The following is a description of a gene set: from publication Kauffmann A, Rosselli F, Lazar V, Winnepenninckx V, Mansuet-Lupo A, Dessen P, van den Oord JJ, Spatz A, Sarasin A (PMID 17891185) We have identified a gene-profile signature for human primary malignant melanoma associated with metastasis to distant sites and poor prognosis. We analyse the differential gene expression by looking at whole biological pathways rather than individual genes. Among the most significant pathways associated with progression to metastasis, we found the DNA replication (P=10(-14)) and the DNA repair pathways (P=10(-16)). We concentrated our analysis on DNA repair and found that genes of this category, among a list of genes, are associated with metastatic progression. These genes belong essentially to the pathways allowing recovery of stalled replication forks due to spontaneous blockage or induced DNA lesions. Because almost all these differentially expressed repair genes were overexpressed in primary tumors with bad prognosis, we speculate that primary melanoma cells that will metastasize try to replicate in a fast and error-free mode. In contrast to the progression from melanocytes to primary melanoma, genetic stability appears to be necessary for a melanoma cell to give rise to distant metastasis. This overexpression of repair genes explains nicely the extraordinary resistance of metastatic melanoma to chemo- and radio-therapy. Our results may open a new avenue for the discovery of drugs active on human metastatic melanoma. DNA repair and replication genes up-regulated in melanoma patients who will relapse vs patients who will not. Human Gene Set: KAUFFMANN_MELANOMA_RELAPSE_UP species: Homo sapiens, and this is the list of marker genes: CTBP2, HUS1, RFC4, PTTG2, TDP1, MCM7, GTF2H2, DEK, CENPF, XRCC5, PPIA (peptidylprolyl isomerase A), POLE4, ORC6, FANCG, TFAM, CHEK1, PTTG1, EXO1, MCM4, CDC45, MCM6, RAD51, MSH2, PCNA, OGG1, DCLRE1A, CHAF1A, GMNN, PMS2P3, EME1, SUMO1, RFC2, RAD17, MCM3, RFC5, GTF2H3, POLQ, RAD18, LAMTOR5, ORC4, SMC4, FANCA, TERF1, RAD54L, CCNH, CDC6, RAD51AP1, TOP2A, NEIL3, MAD2L1, MSH6, BRCA1, RRM2, FANCD2, RPA3, CHEK2, GINS2, BLM, SMC2, BRIP1, XRCC2